The following is a description of a gene set: Abnormal circulating inhibin level species: Homo sapiens Human Gene Set: HP_ABNORMAL_CIRCULATING_INHIBIN_LEVEL Any deviation from the normal concentration of inhibins, which are heterodimeric protein hormones secreted by granulosa cells of the ovary in females and Sertoli cells of the testis in males. Inhibins suppress the secretion of pituitary follicle-stimulating hormone., and this is the list of marker genes: XRCC2, SNRPN, POR, MAGEL2, OCA2, NDN